Given this list of marker genes Taf6, Gtf2h2 (NCBI Gene Id 23894), Taf9, Polr2f, Gtf2h3, Gtf2a1, Taf3, Ak6, Taf9b, Taf12, Taf5, Gtf2f1, Polr2a, Gtf2e1, Polr2k, Taf7, Cdk7, Polr2b, Ercc3, Gtf2h5, Gtf2b, Gtf2e2, Polr2d, Taf2, Gtf2h4, Gtf2f2, Gtf2a2, Taf10, Mnat1, Ccnh, Polr2g, Polr2e (polymerase (RNA) II (DNA directed) polypeptide E), Polr2c (NCBI Gene Id 20021), Polr2h, Taf1, Tbp, Taf13, Taf4b, Polr2i, Taf11, Taf15, Gtf2h1, Polr2l (polymerase (RNA) II (DNA directed) polypeptide L), Taf4, Ercc2, here is a description of the gene set: Mouse Gene Set: REACTOME_RNA_POLYMERASE_II_PROMOTER_ESCAPE species: Mus musculus RNA Polymerase II Promoter Escape